Given this list of marker genes ATG5, ATG7, ATG16L1, ATG12, TSC2, AMBRA1, BECN1, ATG14, VMP1, SH3GLB1, BCL2, TSC1, UVRAG, ATG3, ATG4A, INS, ULK1, MAP1LC3A (NCBI Gene Id 84557), CHAF1A, ATG9B, ATG10, INSR, ULK2, here is a description of the gene set: studied in species Homo sapiens Human Gene Set: WP_NANOPARTICLE_TRIGGERED_AUTOPHAGIC_CELL_DEATH Nanoparticle triggered autophagic cell death